Given this list of marker genes DPT, TAF5, KAZN, DNAJC16, POLR2K, AFF2, FOSL1, COLQ, KRT86, RUNX1, MYC, CAMK2G, TTI1, GPR15, CSTF3, SLC16A5 (solute carrier family 16 member 5), CHD9, NKRF, NUDT13, C1orf216, ZNF200, KYAT1, NTPCR, EP400, WDR62, PAX7 (NCBI Gene Id 5081), CYP11A1, RFC5, SYNJ2, PLEKHB1, SIGMAR1, BRCA1 (NCBI Gene Id 672), UBE2V2, PRELID3A, ZNF330, KRT33A (keratin 33A), MPHOSPH6, GTF2H3, EIF5B, CCNF, MMACHC, TPP2, LPGAT1, SLC4A3, ZBTB14, ARHGAP11A, POLA1, NCKIPSD, PAXIP1, MLN, PHF10, CEP135, NFRKB, FRYL, KANK2, IPCEF1, TRIM27, SCAMP1, SMG1, PPP5C, UBE4B, GRIP2, MUTYH, TAF2, AMFR, SLC2A1, CRHR1, TAF12, ERAL1, ATRX, CLPX, NFX1 (NCBI Gene Id 94733), JRK, HABP4, GRIK5 (glutamate ionotropic receptor kainate type subunit 5), GLE1, TNFRSF25, FDXR, here is a description of the gene set: studied in species Homo sapiens Neighborhood of RFC5 replication factor C (activator 1) 5, 36.5kDa in the MORF expression compendium Human Gene Set: MORF_RFC5 Neighborhood of RFC5